The following is a description of a gene set: from publication Konuma T, Nakamura S, Miyagi S, Negishi M, Chiba T, Oguro H, Yuan J, Mochizuki-Kashio M, Ichikawa H, Miyoshi H, Vidal M, Iwama A (PMID 21540074) Each fraction of mouse hematopoietic cells was purified by cell sorting from bone marrow of 8-week-old C57BL/6 mice, and its gene expression was analyzed. Human Gene Set: GSE27786_LIN_NEG_VS_CD8_TCELL_UP species: Homo sapiens Genes up-regulated in comparison of lineage negative versus CD8 T cells., and this is the list of marker genes: SCRN3, CLEC11A, OIP5, AFG3L2, ACTL6A, PRR18, PML, ZFP30, CENPK, FADS1, DTX4, PDAP1, HSPA5, MLH1 (mutL homolog 1), IRAK1BP1, CCHCR1, KDM2B, PIK3CD, EXOSC5, PMF1, LRRC59, TMBIM4, DACH1, FUT7, ZNF750, TDRD3, PTPN14, COQ4, DNAJB4, PPM1E, DPY19L4, ZWINT, COX7A1, TPK1, CCNF (cyclin F, NCBI Gene Id 899), ABHD14A, PPP1R8, DHX33, CDK2, PHTF2, SLC45A3, TIMM8B, GCNT1, ST7, NUCB1, OTOG, IDH3G, SLC25A1, NUP93, TEX29, GAB2, NFAM1, MMGT1, MFSD13A, ACSL3, ITPRIPL2, CCDC40, FUBP3, PIK3R2, CENPU, PHACTR4, UBE2N, CAMKV, HLX, TRIM13, L2HGDH, YIF1A, ZNF771, DNMT3B, CEP72, AK4, SORT1, RBBP8, TKT, HK2, CHST11, AMMECR1, CYFIP1, TMEM9, ASB8, TPD52L1, DCTD, EGLN3, MYO3A, NUCKS1, GCSH, MPHOSPH6, MRPL42, DARS1, PPM1G, SMO, KIAA1958 (KIAA1958), EIF4B, PSMD12, FZD3, KCTD3, TUFT1, AK3, MCM5, PI4K2B, SCARF1, GSTM4, ENTPD7, HK1, PSMB2, EXOC6, METTL15, MYCT1, GALNT1, DLAT, AQP9, CUTC, LONP1, CSF2RA, STRBP, NUP43, CUL1, DMAC2L, TCEANC, ELMO2, IDH3A, CDCA2, ZDHHC13, FLT3, SMPD4, DPAGT1, TMEM178A, MAGOHB, CRIP2, NUP133, ZDHHC14, FDPS, TGIF2, POLE, SUV39H1, DBI, SLC7A4, AKIP1, CLEC1B, DAB1, RCAN1, PTOV1, LZTFL1, RBM14, MTHFD1L, RBBP7, MGME1, TTLL12, ATL1, NDC1, TTK, TICRR, P2RX4, TPM2, ZNF251, PSME3IP1, GEMIN8, CASP12, RAD51AP1, TRAP1, CCDC146, SYTL4, CDC16, TACC3, MBTPS2, CCDC34, TEX13B, SAMM50, REV1, P4HB, SSR3 (signal sequence receptor subunit 3), SRRT, ABCE1, ZNF449, FARSA, H1-0, SORCS3-AS1, VAT1, VANGL2, HNRNPLL, HSD17B4 (hydroxysteroid 17-beta dehydrogenase 4), CYB5R3, NHSL2, DMWD, METAP2, PRCP, CTNNA1, HIBCH, CDC25A, SLC14A1, LYAR, AAGAB, VDAC3, ZNF516, PDGFD, SLC29A1, OGFRL1, FASTKD5, ANKRD49, PRXL2A